Given this list of marker genes Ahcyl, Ahcy, Tbcel, Lactb, Scimp, here is a description of the gene set: from publication Chen Y, Wang X (PMID 31504780) species: Mus musculus Mouse Gene Set: MIR_1247_3P Genes predicted to be targets of miRBase v22 microRNA mmu_miR_1247_3p in miRDB v6.0 with MirTarget v4 prediction scores > 80 (high confidence targets).